Given this list of marker genes NADSYN1, KYNU, QPRT, IDO2, TDO2, NMNAT2, AFMID, IDO1, NMNAT3, HAAO, NMNAT1, KMO, here is a description of the gene set: Pathway Definition from KEGG: Trp -- (TDO2,IDO1/2) >> AFMID -> Kyn -- KMO >> KYNU >> HAAO >> QPRT >> NMNAT >> NADSYN1 -> NAD+ studied in species Homo sapiens NAD biosynthesis. Pathway ID: N01723. Pathway type: Reference. Pathway class: nt06036 Lysine degradation. Human Gene Set: KEGG_MEDICUS_REFERENCE_NAD_BIOSYNTHESIS